The following is a description of a gene set: Catalysis of the transfer of a nitrogenous group from one compound (donor) to another (acceptor). species: Homo sapiens Human Gene Set: GOMF_TRANSFERASE_ACTIVITY_TRANSFERRING_NITROGENOUS_GROUPS, and this is the list of marker genes: BCAT1, BCAT2, GPAA1, CISD1 (NCBI Gene Id 55847), ABAT, GFPT1, GPT, GOT1L1, GAPDH, MGAT4A, AADAT, PIGK, ACCS, GPT2, OAT, NOS1, TAT, PHYKPL, AGXT2, KYAT1, AGXT, KYAT3, GOT1, PSAT1, ACCSL, ETNPPL, PIGU, GOT2, GFPT2, BLVRB, AMT